The following is a description of a gene set: studied in species Homo sapiens Human Gene Set: GOBP_POLYSACCHARIDE_CATABOLIC_PROCESS The chemical reactions and pathways resulting in the breakdown of a polysaccharide, a polymer of many (typically more than 10) monosaccharide residues linked glycosidically., and this is the list of marker genes: AGL, ADCY10, RB1CC1, PYGL, GABARAPL1, ATG2A, WIPI1, ATG12, PPP1R3B, STBD1, ATG2B, PYGM, PYGB, MGAM, GAA, PPP1CA, CHIA, G6PC1, PHKA1, WDR45B, INS, PGM2, PHKG2, PPP1R3D, CHIT1, PFKM, ATG3, WDR45, WIPI2, HMGB1